The following is a description of a gene set: from publication Cui A, Huang T, Li S, Ma A, Pérez JL, Sander C, Keskin DB, Wu CJ, Fraenkel E, Hacohen N (PMID 38057668) studied in species Mus musculus Genes positively differentially expressed in cell type: Macrophage upon treatment with cytokine: Leptin in mouse lymph nodes in vivo. Mouse Gene Set: CUI_MACROPHAGE_LEPTIN_RESPONSE_UP Cytokines mediate cell-cell communication in the immune system and represent important therapeutic targets. A myriad of studies have highlighted their central role in immune function, yet we lack a global view of the cellular responses of each immune cell type to each cytokine. To address this gap, the authors created the Immune Dictionary, a compendium of single-cell transcriptomic profiles of more than 17 immune cell types in response to each of 86 cytokines (>1,400 cytokine-cell type combinations) in mouse lymph nodes in vivo. A cytokine-centric view of the dictionary revealed that most cytokines induce highly cell-type-specific responses. For example, the inflammatory cytokine interleukin-1β induces distinct gene programmes in almost every cell type. A cell-type-centric view of the dictionary identified more than 66 cytokine-driven cellular polarization states across immune cell types, including previously uncharacterized states such as an interleukin-18-induced polyfunctional natural killer cell state., and this is the list of marker genes: Ifi204, Ifitm3, Slfn8, Fcgr1, Sp100, Ifih1, Ifit3, Irf7, Ifi47 (NCBI Gene Id 15953), Ifit2